The following is a description of a gene set: species: Homo sapiens Human Gene Set: GOCC_EUCHROMATIN A dispersed and relatively uncompacted form of chromatin that is in a transcription-competent conformation., and this is the list of marker genes: SP1, SETD5, ALKBH1, NSMF, SIRT1, EXOSC3, H2AB2, ANKRD2, ICE1, TRNP1, H1-0, H1-5, CREB1, POU4F2, HIF1A, ESR1, H1-4, DNMT3A, JAK2, ZC3H8, H1-2, KLF4, MYC, UHRF1, H2AB1, RUVBL2, KMT2E, TCF3, H1-3, DNTT, H2AZ1, EXOSC4, RRP1B, PSIP1, H2AB3, CTR9, TCF23, CBX2, H1-1, TRIM24, ELL, SKIC8, HSF1, BCAS3, TBP, MYOD1 (NCBI Gene Id 4654), RBMX, ID2, RNF2, SKIC3, EXOSC10, H3-5, CECR2, ICE2, JUN, EXOSC5, NR1H4, CBX3, TRIM28, PADI2, AFF4, PELP1, CTNNB1